The following is a description of a gene set: Human Gene Set: GOMF_GUANYLATE_CYCLASE_ACTIVITY Catalysis of the reaction: GTP = 3',5'-cyclic GMP + diphosphate. studied in species Homo sapiens, and this is the list of marker genes: NPR2, GUCY1B1, NCS1, GUCY1A2, GUCA1C, GUCA1ANB-GUCA1A, RCVRN, GUCY1A1, GUCA1B, GUCA1A, GUCY2D, GUCA2A, GUCY2F, GUCA2B (NCBI Gene Id 2981), NPR1, GUCY2C, NHERF4 (NHERF family PDZ scaffold protein 4)